The following is a description of a gene set: species: Mus musculus Mouse Gene Set: GOCC_SYNAPTOBREVIN_2_SNAP_25_SYNTAXIN_1A_COMPLEX A SNARE complex that contains synaptobrevin 2 (VAMP2), SNAP-25, and syntaxin 1a (or orthologs thereof)., and this is the list of marker genes: Napa, Snap25, Napb, Stx1a, Vamp2